Given this list of marker genes Gng10, Taldo1 (transaldolase 1), Gng7, Prkca, Kcnb1, Gng3, Adra2a, Gna14, Adipor1, Gngt2 (NCBI Gene Id 14710), Kcnj11, Adra2c, Prkar2b, Gnb2, Cd36, Gnai1, Prkacb, Adipoq, Gcg, Gng4, Gcgr, Gnb3, Cacna2d2, Ffar1, Acsl4, Cacna1a (calcium channel, voltage-dependent, P/Q type, alpha 1A subunit), Marcks, Gng8, Gng5, Adcy5, Cacnb3, Kcng2, Adipor2, Prkaca, Gngt1, Tkt, Glp1r (NCBI Gene Id 14652), Gnb5 (NCBI Gene Id 14697), Gng11, Plcb3, Prkar1b, Slc2a1, here is a description of the gene set: This event has been computationally inferred from an event that has been demonstrated in another species.<p>The inference is based on the homology mapping from PANTHER. Briefly, reactions for which all involved PhysicalEntities (in input, output and catalyst) have a mapped orthologue/paralogue (for complexes at least 75% of components must have a mapping) are inferred to the other species. electronically inferred by orthology from the curated human pathway species: Mus musculus Reactome Pathway: Integration of energy metabolism part of: Metabolism